The following is a description of a gene set: The involvement of the c-Myc transcription factor in neoplastic transformation is well documented. However, which of its numerous target genes are crucial for tumorigenesis remains a frequently contested issue. We have recently established a non-transgenic murine model for B-cell lymphoma based on neoplastic conversion of p53-null bone marrow cells by conditionally active Myc. Using this model, we have identified a number of genes whose expression levels are affected by Myc during B-lymphomagenesis. Here we discuss their possible roles in neoplastic processes and describe an experimental approach allowing in vivo validation of these roles. We demonstrate that lymphoma cells overexpressing one of the Myc targets, the interleukin-10 receptor gene, have a very strong selective advantage over low IL10R expressors. Furthermore, Mcl1, a presumptive IL10R effector, also confers selective advantages when overexpressed in Myc-transformed hematopoietic cells. Thus, both IL10R and Mcl1 might be amenable to therapeutic interventions, and new targets can be identified and validated using the selection approach. Genes up-regulated in B cell lymphoma tumors expressing an activated form of MYC. from publication Yu D, Cozma D, Park A, Thomas-Tikhonenko A (PMID 16382050) Human Gene Set: YU_MYC_TARGETS_UP species: Mus musculus, and this is the list of marker genes: FDPS, NUP54, ANLN, YBX3, TSPAN4, ASPM, ECT2, MKI67, CKS1B, GMNN, CDK1, NUDCD2, BUB1, CLIC4, CKS2, KPNA2, HMGN2, FAM136A, STRAP, TXN, HMGB2, TFDP1 (transcription factor Dp-1), BIRC5, PCLAF, TOP2A, CCNB2, RACGAP1, HNRNPLL, UCHL5, CDKN3, CCNB1, PLK1, PCNA, DCTPP1, RRM1, KIF20A, BRCA2, E2F8, DTL, AURKA, UBE2S, IDI1, GSDME